Given this list of marker genes PRNP, NR1H4, RAI1, FLII, ATP8B1, ABCB4, IQSEC2, ABCB11, DEAF1, here is a description of the gene set: species: Homo sapiens Human Gene Set: HP_ABNORMALITY_OF_PINEAL_PHYSIOLOGY A functional abnormality of the pineal gland. Abnormality of pineal physiology